The following is a description of a gene set: studied in species Homo sapiens Human Gene Set: OHM_METHYLATED_IN_ADULT_CANCERS from publication Ohm JE, McGarvey KM, Yu X, Cheng L, Schuebel KE, Cope L, Mohammad HP, Chen W, Daniel VC, Yu W, Berman DM, Jenuwein T, Pruitt K, Sharkis SJ, Watkins DN, Herman JG, Baylin SB (PMID 17211412) Adult cancers may derive from stem or early progenitor cells. Epigenetic modulation of gene expression is essential for normal function of these early cells but is highly abnormal in cancers, which often show aberrant promoter CpG island hypermethylation and transcriptional silencing of tumor suppressor genes and pro-differentiation factors. We find that for such genes, both normal and malignant embryonic cells generally lack the hypermethylation of DNA found in adult cancers. In embryonic stem cells, these genes are held in a 'transcription-ready' state mediated by a 'bivalent' promoter chromatin pattern consisting of the repressive mark, histone H3 methylated at Lys27 (H3K27) by Polycomb group proteins, plus the active mark, methylated H3K4. However, embryonic carcinoma cells add two key repressive marks, dimethylated H3K9 and trimethylated H3K9, both associated with DNA hypermethylation in adult cancers. We hypothesize that cell chromatin patterns and transient silencing of these important regulatory genes in stem or progenitor cells may leave these genes vulnerable to aberrant DNA hypermethylation and heritable gene silencing during tumor initiation and progression. Genes showing frequent DNA methylation and which are silenced in adult cancers but remain unmethylated in embryonic carcinoma and embryonic stem (ES) cells., and this is the list of marker genes: THBS1, SFRP5, DAPK1, MLH1, RASSF1, SFRP4, HIC1, ESR1, CDKN2A, SOCS1, TP73, SFRP2, FHIT, GATA5, FANCF, TIMP3, BRCA1, CDH1, GSTP1, RARB, SFRP1, CCND1, PYCARD, CDKN2B, RBP1, MGMT, GATA4